The following is a description of a gene set: Reactome Pathway: Loss of Nlp from mitotic centrosomes part of: Loss of proteins required for interphase microtubule organization from the centrosome electronically inferred by orthology from the curated human pathway This event has been computationally inferred from an event that has been demonstrated in another species.<p>The inference is based on the homology mapping from PANTHER. Briefly, reactions for which all involved PhysicalEntities (in input, output and catalyst) have a mapped orthologue/paralogue (for complexes at least 75% of components must have a mapping) are inferred to the other species. studied in species Mus musculus, and this is the list of marker genes: Clasp1, Nedd1, Prkaca, Cep41, Sfi1, Cep290, Dynll1, Haus7, Cep72, Cdk1, Haus1, Cep131, Haus5, Prkar2b, Cep152, Ninl, Tubb4b, Csnk1e, Ywhae, Tuba4a, Nde1 (NCBI Gene Id 67203), Cep192, Sdccag8, Plk1, Cep43, Tubb4a, Tuba1a, Dctn1, Actr1a, Cenpj, Cep63, Cep57, Haus8, Cep135